Given this list of marker genes LEP, DCAF15, IL15RA (NCBI Gene Id 3601), TYK2, STAT5A, IL15, PTPN22, IL18, KLRD1, CLEC12A, AXL, IL12B, IL21, STAT5B, BLOC1S6, IL12A, MICA, RASGRP1, TOX, BLOC1S3, PGLYRP1, PRDM1, KLRC1 (NCBI Gene Id 3821), ZBTB1, HLA-E, GAS6, RHBDD3, FCGR3A, FGR, CLNK, IL23A, JAK2, KLRC2, ZNF683, MIR130A, PIBF1, IL23R, PGLYRP2, TYROBP, RPL13A, PGLYRP3, KLRC3, FLT3LG, TICAM1, HAVCR2, here is a description of the gene set: studied in species Homo sapiens Human Gene Set: GOBP_REGULATION_OF_NATURAL_KILLER_CELL_ACTIVATION Any process that modulates the frequency, rate or extent of natural killer cell activation.